The following is a description of a gene set: from publication Chen Y, Wang X (PMID 31504780) Human Gene Set: MIR548I studied in species Homo sapiens Genes predicted to be targets of miRBase v22 microRNA hsa-miR-548i in miRDB v6.0 with MirTarget v4 prediction scores > 80 (high confidence targets)., and this is the list of marker genes: RFC3, ITGAV, TMEM65, ANKRD26, BNIP3, RGPD6, RNF149, PPARG, KLF10, RGS7BP, RRAGD, ZBTB41, TCF12, MBNL2, GULP1, SRSF6, FGD4, FRMD5, TTC13, RORA, SLC30A5, NOTUM, ADAMTS1, GUCY1B1, TPM3, LVRN, PGAM1, NDC1 (NDC1 transmembrane nucleoporin), FAM135A, ADAMDEC1, CBX3 (chromobox 3), GPATCH11, ZNF680, TRAM1, SF3A1, DYNC1I2, MMP16, A1CF, KCNJ3, HMBOX1, OAZ1, ATP11A, NFAT5, LIN7A, GRM5, TMEM167B, CFDP1, ZNF559, KLF8, NDFIP2, CISD2, DUSP7, LATS1, MTF1, CLCN4, ASB3, UTP3, GRIP1, DYNC1LI2, POLR2H, LSAMP (limbic system associated membrane protein), CARF, SERINC5, PPEF2, SAMD8 (NCBI Gene Id 142891), FNDC3B, RAB8B, CEP120, PTPRG, SIX4, MBIP, LRP1B, NAV2, RBBP8, URI1, SCARF1, ELL2, FAM133A, ARL13B, ANAPC1, LRRTM3, STXBP5, PHYHIPL, SSR3, TMEM135, MMUT, ACTN4, WAPL, PLEKHH2, CAPN2, HOXD13, CCNB1, RPS6KA5, AFDN, SNX16, MFN1, COMMD3-BMI1, PRPF39, MYCN, BEND7 (BEN domain containing 7), ZNG1C, SCN1A, DEFA6, PCDH11Y, SCN8A, CCP110, ZBTB11, ZNF792, FBXL3, C3orf38, SOX5, LCTL, RNF138, CA8, BRWD3, ADGRB3 (adhesion G protein-coupled receptor B3), TFDP3, KRT28, RICTOR (RPTOR independent companion of MTOR complex 2), MEX3D, CFL2, GCC2, ITGB6, ANKRD46, ADAM22, RFX7, COL11A1, ZBTB25, LCOR, LPP, CCDC179, CLVS2 (NCBI Gene Id 387358), CDK6, RAP2A, ACADL, C11orf87, SH3D19, ADAM30, PROSER1, NR2C1, BBX, SLC4A7, CTNNA3, LRRC7, UEVLD, KLRD1, PCLO, PLEKHG1, CBFB, FGL2, CERS6, ACBD5, PRP4K, ERC2, SEC22C, FEM1C (fem-1 homolog C), RIC1, ZNF454, CNTN1, SCN3A, OGFRL1, SACS, EEA1, TMTC3, XPNPEP1 (NCBI Gene Id 7513), CIAO2A, HDAC9, TP53INP1, GPD2, HOOK3, B3GALT5, TIFAB, ACVR2B, SMAD9, FAM199X, FMNL2, RASSF8, CYBRD1, ATXN7L1 (ataxin 7 like 1), CEP350, GPALPP1 (NCBI Gene Id 55425), PCDH11X, RETREG1, SETD2, TTC19, MTA1, GLIPR1, IGF1, GOLGA6L2, ADH5, SPAG9, ARRDC4, STEAP2, SLCO5A1, CACNA2D3, PPHLN1, ZNF747, TBCK, MED6, DNAJB4, FYB2, MIER3, NUP160, AGTR1, ARMCX3, PAQR9, ZNF492, CHST9 (NCBI Gene Id 83539), SESTD1, SUMF1, ZNF486, EXOC5, IKZF2, CHN1, CCDC117, MZT1, ANGEL2, PSMC2, MDFIC (MyoD family inhibitor domain containing), PRRC1, PDZRN4, SANBR, HECA, LMCD1 (NCBI Gene Id 29995), SNX30, BBS10, TMED7, SFT2D1, SECISBP2L, PPP1R27, TRA2B (NCBI Gene Id 6434), ARL6IP6, BCL2L2, GPR85, WDR47, UBA6, MAST3, TRPC1, ZNF148, SLU7, DENND1B, TRIM9, KL, ALG11, CCNG2, RHPN2, NEDD4L, GABRA4, CAMSAP2, TMEM200A, SLAIN1, CRACD, DHRS1, PRKAA1, ZNF608, BTG3, ZDHHC15, GPR155, ZNF652, SLC24A3, KPNA4 (NCBI Gene Id 84857), LACTB, NUP50, NCKAP1, TXLNG, EIF2AK2, ZEB2, DNAJB14, SDC2, SERINC3, DCDC2, PRKAG2, PDE4D, TMEFF2 (NCBI Gene Id 51753), WDR26, NTF3, KLF7, NOS2, RGPD5, NAT1, JARID2, GSTCD, ZNG1B, PTGFRN, SRP9, DAAM1, KIAA1586, CD99, AQP3, TRIM2, FOXG1, TNFRSF21, ZDHHC21, PTPRR, ZNG1E, ZBTB10, BMI1 (NCBI Gene Id 648), FSBP, PROK2, MCF2L2, TLCD4, IGSF3 (immunoglobulin superfamily member 3), C21orf91, RHOQ, SPOCK3, ZBTB44, TRPC5, LARP4, SPDYE1, SENP1, FNIP2, EVI2A, DTWD2, MBNL3, RIMOC1, S1PR1, C9orf40, FZD3, ZNF326, MINDY2, BTF3L4, PPP5C, HOMER1, MAST4 (NCBI Gene Id 375449), MIDEAS, MIGA1, SKIDA1, MFSD8, CCDC47, SNAP91, WDR7, SDF4 (NCBI Gene Id 82832), CLDN12, CCDC50, SDE2, PITX2, ZDHHC2, PRKG1, RAB27B, REV3L, HLTF, PDE1C, BRWD1, KATNBL1, SREK1, ANKRD22, MTFR1, SCAI (NCBI Gene Id 286205), HIPK1, GATM, MAP4K4, PPP1R2 (protein phosphatase 1 regulatory inhibitor subunit 2), CD163, CFAP44, THSD7A, ABCA5, MMD, AHSA2P, RC3H1, GASK1A, FIGN, KIF20B, NRXN1, PAX5, DIP2B, TRUB1, ETF1, SAMTOR, RNF217, LANCL1, TBCA, PTBP3, ZNG1A, PAPOLG, TOLLIP, DDIT4, TFAM, ZRANB2, ODAPH, ZBTB8A, ZFAND5, STYX, MAGT1, ARK2N, SPATA6L, UGDH, CSGALNACT2, EPB41L5, BOD1L1, METTL6, PRELID2, SYNM, ZNF503, GRID2, ZC3HAV1L, MGARP, RGPD4, DIAPH3, AIDA, AK3, CCSER1 (coiled-coil serine rich protein 1), RO60, SCML2, SRSF3, DPY19L3 (NCBI Gene Id 147991), LRRC4B, RESF1 (NCBI Gene Id 55196), ZBTB20, TMTC1, CHRNA7, CMPK2, MECP2, LMX1A, RALA, UBE2A, GCNT1, ABI3BP (NCBI Gene Id 79859), NFKB1, DOLPP1 (dolichyldiphosphatase 1), UGT8, FZD7, AP1AR, YIPF5, NUP54, RMND5A, U2SURP, AFTPH, SYTL5, MEIS2, NRG4, GTF3C3, SEC24A, FGFR1OP2, MIER1, PRKAA2, ARID2, PREX2 (NCBI Gene Id 80243), CSNK1D, NOTCH2, GUCY1A2, CAMLG, ME1 (NCBI Gene Id 4199), ACBD3, IGF2BP3, SFMBT1 (NCBI Gene Id 51460), NEGR1, PRPF40A, RAP1A, SCAMP1, APPBP2, PPP1R9A, GSE1, RGPD8, FAM221A, NUMB, ZCCHC8, PDCD5, PGRMC2, FLRT3, UNC80, GABPA, C5orf24, IKBIP, HNRNPDL, TMEM255A, BTG2, CCNY, MAML1, DUS4L, MAP9, EPHA3, C6orf120, EDIL3, ATXN2 (NCBI Gene Id 8095), GOPC, GAPVD1, GRM7, GNAQ, CRIPT, METTL8, GPC6, ACAT2, ANKRD10, ARFRP1, CACUL1, NAA30, GABPB1, LACTB2, SMG1, MARCHF6, SMAD5, FZD5, HTR2C, ZNG1F